The following is a description of a gene set: A deviation from the normal number of mitochondria per cell. species: Homo sapiens Abnormal mitochondrial number Human Gene Set: HP_ABNORMAL_MITOCHONDRIAL_NUMBER, and this is the list of marker genes: PET117, GYG1, CHCHD10, SFXN4, DNA2, MGME1